Given this list of marker genes Trim62, Slc3a2, Trim38, Uvrag, Lgals1, Dynlt1b, Bcl2l11, Fuca2, Insr, Vapb, Cd209e, Kpna6, Agtr1a, Vps4b, Avpr1b, Zfp639, Pikfyve, Slc20a2, Ist1, Slamf1, Trim30b, Pglyrp4, Cldn1, Chmp3, Trim5, Vps18, Tyro3, Ilf3, Hmgb1, Tmprss11d, Vamp8, Cd300ld, Trim12a, Cd81, Cd300lf, Chmp2a, Chmp4b, Gbp3, Dynlt1c, Ceacam1, Cav2, Axl (AXL receptor tyrosine kinase), Vps4a, Cd209d, Pglyrp2, Siglec1, Chmp1b2, Furin (furin, paired basic amino acid cleaving enzyme), Lrrc15, Tpcn1, Tpcn2, Smpd1, AU040320, Ddb1, Trim11, Nectin4, Rab7, Ppara, Vps16, Cd4, Bpifa5, Pcx, Gas6, Akt1, Gbp2, Tmprss4, Xpr1, Vps37b, Eps15, Trim30c, Ace2 (angiotensin converting enzyme 2), Gpr15, Arl8b, Siva1, Fbln1 (NCBI Gene Id 14114), Trim12c, Trim30a, Gbp9, Rnasek, Hyal2, Dynlt1a, Gbp2b, P4hb, Agtr1b, Hsp90ab1 (NCBI Gene Id 98078), Chmp2b, Gbp7, Cldn6, Trim30d, Cd74, Cldn9, Spint1, Myh9, Chmp1b, Tsg101, Itgb3, Tmprss2, Slc7a1 (NCBI Gene Id 264068), Bad, Npc1, Hspd1, Clec4g (C-type lectin domain family 4, member g), Gbp6, Ctsb, Chmp4c, Tmprss11e, Jpt2, Vapa, Nectin1, Chmp5, Dpp4, Nrp1, Dag1 (dystroglycan 1), Nectin2, Trim25, Itgav, Chmp1a, Tmprss11a, Dynlt1f, Naip5, Icam1, Cd209c, Pglyrp3, Cav1, Exoc2, Chmp7, Trim31, Grk2, Bsg, Clec5a, Pglyrp1, Hs3st5, Ch25h, Tnfrsf14, Ltf, Avp, Exoc7, Nectin3, Bpifa1, Phb1, Scarb1, Chmp6, Becn1, here is a description of the gene set: studied in species Mus musculus Mouse Gene Set: GOBP_BIOLOGICAL_PROCESS_INVOLVED_IN_INTERACTION_WITH_HOST An interaction between two organisms living together in more or less intimate association. The term host is used for the larger (macro) of the two members of a symbiosis; the various forms of symbiosis include parasitism, commensalism and mutualism.